Given this list of marker genes PAX6, SIM1, WT1 (NCBI Gene Id 7490), PTPN22, IFNG, SLC25A15, TSC2, MAGEL2, VPS33A, FAS, DCT (NCBI Gene Id 1638), TSC1, here is a description of the gene set: Human Gene Set: HP_CHORIORETINAL_HYPOPIGMENTATION studied in species Homo sapiens Chorioretinal hypopigmentation